Given this list of marker genes CD69, LRCH1, IL27RA, APOD, RIPOR2 (NCBI Gene Id 9750), CD200, MIA3, GCSAM (germinal center associated signaling and motility), KLRK1, PADI2, AKT1, CCL2 (C-C motif chemokine ligand 2, NCBI Gene Id 6347), ADTRP, WASL, KLRC4-KLRK1, CD200R1, here is a description of the gene set: studied in species Homo sapiens Any process that stops, prevents or reduces the frequency, rate or extent of lymphocyte migration. Human Gene Set: GOBP_NEGATIVE_REGULATION_OF_LYMPHOCYTE_MIGRATION